The following is a description of a gene set: species: Mus musculus Mouse Gene Set: GOBP_DNA_PROTECTION Any process in which DNA is protected from damage by, for example, oxidative stress., and this is the list of marker genes: Ercc6, Dctpp1 (NCBI Gene Id 66422), Nudt15, Cbs, Nudt1